Given this list of marker genes SORD, GK, MIOX, NTSR1, GK2, TPI1, NUDT3, TKFC, GK5, GPD2, here is a description of the gene set: The chemical reactions and pathways resulting in the breakdown of a polyol, any alcohol containing three or more hydroxyl groups attached to saturated carbon atoms. studied in species Homo sapiens Human Gene Set: GOBP_POLYOL_CATABOLIC_PROCESS